The following is a description of a gene set: Genes down-regulated in SARS-CoV-2 infection (ACE2 expressing A549 cells, MOI: 2, 24hpi) Human Gene Set: BLANCO_MELO_COVID19_SARS_COV_2_INFECTION_A594_ACE2_EXPRESSING_CELLS_DN species: Homo sapiens from publication Blanco-Melo D, Nilsson-Payant BE, Liu WC, Uhl S, Hoagland D, Møller R, Jordan TX, Oishi K, Panis M, Sachs D, Wang TT, Schwartz RE, Lim JK, Albrecht RA, tenOever BR (PMID 32416070) Analysis of the transcriptional response to SARS-CoV-2 compared with other respiratory viruses, including MERS-CoV, SARS-CoV-1 (SARS), human parainfluenza virus 3 (HPIV3), respiratory syncytial virus (RSV), and IAV., and this is the list of marker genes: TSPAN7, PCDHA4, FAM149A, ASB9, SMPDL3B, PSAT1, SKP2, BCAS1, SLC40A1, AHCY, TM7SF2, RAB26, WDR18, DPYSL5, KLHL4, ALDH1A1, CROT, AKR1C4, PSAP, EPHX1, APOH, SERPINI1, SVEP1, SLC25A10, ANK1, SLC51B, CDK5, RERG, NRXN3, GPX2 (NCBI Gene Id 2877), PRPS1, PRDX1, MCM5, SPP1, OLFML2A (olfactomedin like 2A), GATM, NDUFA13, ADI1 (NCBI Gene Id 55256), FGFR3, DDC, METRN, SLC25A11, ALDH3A2 (NCBI Gene Id 224), F2RL2, CNTN1, CDH17, F5, CNFN, PBXIP1, NDUFS7, TMT1B, ATP6V0E2, TUBB4A (tubulin beta 4A class IVa), PDGFD, DCDC1, SFRP4, TK1, GSTM4, ANXA13, MAPRE2, FLRT2 (NCBI Gene Id 9822), KRT4, IGFBPL1, INSL4, KCNAB2, KCNJ16, MXD4, HADH, GPC1, CYBA, PDK2, DSC3 (NCBI Gene Id 1825), SERPINH1, ETFB, SCARA5, C5, NDUFB10, CLTRN, UCP2, BST1, AMBP, CENPM (centromere protein M), TCTN3, TNFSF15, COL21A1, FFAR4, SWI5, SLCO2B1, HABP2, TPPP3, TPD52L1, RRM2, TRIM2, NDUFA2, SEMA3E, ANXA2